Given this list of marker genes ATXN1, ANXA2P2, SEC61A1 (NCBI Gene Id 83289), PLEKHA5, PPIF, REEP3, NQO1, PLIN2, LRRC61, UHRF1, SNX5, NSDHL, SRGAP2, TFE3, LPCAT3, NUSAP1, H3C12, ARHGAP11B, HERPUD1, ELL2, TPP1, CENPI, NRBP1, FHIP2A, GLA, MSC, PLEKHA2, WSB2, SMCO4, CD82, KCTD6, CCNE1 (NCBI Gene Id 898), INPP1, H3C10, PDE1B, CKS2, IQGAP2, YEATS2, ANXA5, ADAM19, ANKRD28, CERS2, CPOX, MAP3K20, NARF, ARL6IP1, FADS2, CHEK1, DDB2, TARS1, CTNNA1, CD81, PFKP, AIFM1, DNAI3, DCTN2, TMEM60, SYT11, NIBAN1, REEP4, TMEM120A, SNORA71C, JPT1, CD58, PPP1R16B, NPC1, NCKAP1L, DSCC1, ADAM9, LY96, NCF4, HRH4, H2AC14, TP53INP1, KCNAB2, IFI35, HERC5, TKT, NANS, KDSR, AKR1A1, PARK7, HMGCR, TFRC, GEMIN7, DCAF7, PCGF1, PAM, LIMD1 (LIM domain containing 1), GMNN, ACOT9, TM7SF2, PDIA6, NEIL3, SSNA1, S100A11, TACC1, PLEKHO2, POGLUT2, NCOA7, PDXDC1 (pyridoxal dependent decarboxylase domain containing 1), DNAAF2, DNPH1, LDLR, ARHGAP18, BAK1, ATOX1, GPR15, G6PD, INTS7 (integrator complex subunit 7), SLC15A4, CCR4, MAP4K1, KIF18A, ATP6V0D1, TTL, AIM2, CASP3, RPN1, FDPS, RNF19A, CHP1, CD28, IDH1, GLMP, KIF11, TXNRD1 (NCBI Gene Id 7296), COLGALT2, PCK2, BCL2L1, RILPL2, CDCA4, STXBP1, SGO1, BMAL2 (basic helix-loop-helix ARNT like 2), YIPF1, ANKRD13B, DUSP16, DHCR24, ACTN4, ACTA2, H4C13, ANXA4, SEPTIN8, H2BC10, STOM, RPS6KA1, DUSP10, TGFBR3, RAPGEF2, P2RX7, JAK2, GLCCI1, S100A4, FZD6 (frizzled class receptor 6), ACAT1, SNTB2, STK39, PRKAG1, SEC14L1, GPR68, CTSC, DNAJC1, TUBB4B, CLTC, GBA1, KCNA2, EMC7, PIK3R3, ICMT, MCOLN2 (NCBI Gene Id 255231), RAB8B, TIFA, GLB1, SH3BGRL3, ACSL4, LMO4, CDC34, SLC35B2, CORO1C, MVD, F2R, SPX, MAN1A1, STARD4, CTSA, GK, NCR3, MCM2, RAD23B, CD2, ZC2HC1A, LPXN, RNF135, PRDX3, PARVB, CD63, WEE1, SLFN11, TRIP10, here is a description of the gene set: studied in species Homo sapiens Human Gene Set: GSE32986_GMCSF_VS_GMCSF_AND_CURDLAN_LOWDOSE_STIM_DC_UP Genes up-regulated in bone marrow-derived dendritic cells CSF2 versus CSF2 and low dose of 1,3-beta-D-oligoglucan. A simultaneous engagement of different pathogen recognition receptors provides a tailor made adaptive immunity for an efficient defence against distinct pathogens. For example, cross talk of TLR and c-type lectin signalling effectively shapes distinct gene expression patterns by integrating the signals at the level of NF-κB. Here, we extend this principle to a strong synergism between the Dectin-1 agonist, curdlan, and an inflammatory growth factor, GM-CSF. Both together act in synergy in inducing a strong inflammatory signature which converts immature DCs to potent effector DCs. A variety of cytokines (IL-1β, IL-6, TNF-α, IL-2 and IL-12p70), costimulatory molecules (CD80, CD86, CD40 and CD70), chemokines (CxCl1, CxCl2, CxCl3, CCl12, CCl17) as well as receptors and molecules involved in fugal recognition and immunity such as Mincle, Dectin-1, Dectin-2 and Pentraxin 3 are strongly up-regulated in DC treated simultaneously with curdlan and GM-CSF. The synergistic effect of both stimuli resulted in strong IKBα phosphorylation, in its rapid degradation and in enhanced nuclear translocation of all NF-κB subunits. We further identified MAPK ERK, as one possible integration site of both signals, since its phosphorylation was clearly augmented when curdlan was co-applied with GM-CSF. Our data demonstrate that the immunomodulatory activity of curdlan requires an additional signal provided by GM-CSF to successfully initiate a robust β-glucan specific cytokine and chemokine response. The integration of both signals clearly prime and tailor a more effective innate and adaptive response against invading microbes and fungi. from publication Min L, Isa SA, Fam WN, Sze SK, Beretta O, Mortellaro A, Ruedl C (PMID 22250091)